The following is a description of a gene set: studied in species Mus musculus Catalysis of the reaction: protein tyrosine phosphate + H2O = protein tyrosine + phosphate. Mouse Gene Set: GOMF_PROTEIN_TYROSINE_PHOSPHATASE_ACTIVITY, and this is the list of marker genes: Ptpn20, Ssh3, Ptprf, Dusp13b, Ptpn13, Ptpn23, Ptpn1, Ptp4a3, Eya1, Acp3, Cdkn3, Dusp22, Ptprs, Ptpn11, Igfbp3, Mtmr4, Dusp14, Ptprn, Dusp6, Ptp4a1, Epm2a, Dusp28 (NCBI Gene Id 98616), Ptprd, Ptpru, Ptpre, Ptprk, Ptpn14, Ptprm, Dusp18, Ptpn7, Dusp8, Ptpn18, Ptpmt1, Mdp1, Cd33, Pten, Cdc14b, Ptpn3, Acp4, Mtmr3, Ptpn22, Dnajc6, Pald1, Cdc25a, Cdc14a, Ptpn9, Cdc25c, Ptprb, Dusp11, Dusp2, Dusp29, Ptprr, Ptpa, Eya3, Dusp9, Dusp10, Ppp2ca, Dusp13a, Ssh2, Dusp12 (dual specificity phosphatase 12), Ptprg, Dusp3, Tns2, Ptprz1, Dusp26, Ptprt, Ptp4a2, Timm50, Ptpro, Ptpn5, Dusp1, Eya2, Ptprj, Ptprc, Dusp21, Ptprq, Dusp7, Eya4, Dusp16, Ptpn12, Slc39a10, Ptk2, Ptprn2, Ssh1, Dusp15, Acp1, Ptpdc1, Ptpra, Ubash3b (NCBI Gene Id 72828), Dusp4, Ptpn21, Ptpn6, Dusp19, Cdc25b, Ptpn4, Ptprh, Ptprv, Ptpn2, Pgp, Dusp23